Given this list of marker genes PCDHA12, CASZ1, AFF3, ELAPOR2, MSRB3, HEYL, SLC12A5, CHGA, KLK15, SH3BP5L, ALS2CL, DDN, VASH1, PRKAR2A, DSE, PCDHA13, ZNF710, CEP89, PSD3, PCDHA1, PHLPP1, PCDHA3, LMO4, POP1, FHIP2A, UNK, LPAR5, TP53INP2, PCDHA10, TRMT112, PCDHAC1, PCDHA4, BLTP2, PCDHA2, LMX1A, SH3PXD2A, TEF, ETV5 (ETS variant transcription factor 5), PRR12 (NCBI Gene Id 57479), NSMF (NMDA receptor synaptonuclear signaling and neuronal migration factor), TXNRD1 (NCBI Gene Id 7296), LIMD2, USP46, GPR132, SMNDC1, PCDHA8, CIMIP1, ZBTB39, ZNF239, IGFBPL1, PCDHA5, CASTOR2, SLC38A4, SYNJ1, KCNQ1, PAX3, FAM53C, PBX1, ARID3B, TBCEL, PIP4P1, LHFPL6, ADCY1, NUP58, MYO1B, TMEM184A, OVOL1, KCNK9, RAP1GAP, TMEM131, PCDHA11, SH3TC2, RFTN1, C2orf49, DHDDS, IST1, HSPB7, MXI1, PCDHA6, MICOS10, EDEM1, UBE2QL1, BCL2L13, COX6C, LHX1, RGP1, ZDHHC3, TRAPPC3L, PCDHA7, ADD2, SLC6A3, YEATS2, MMP28, RAB43, EPHB2, ADAMTS14, KAZN, PRDM1, ELOVL5, KIRREL3, RNF4, BSN, PTPN12, PLEKHB2, TIMM22, ATP8A2, HTR2C, EPHA10, PCDHAC2, KDM4A, GRIK3, DOCK3, PCDHA9 (NCBI Gene Id 9752), TMEM47, PTCHD4, SNX12, NUFIP2, FGF3, KATNIP, here is a description of the gene set: studied in species Homo sapiens Human Gene Set: MIR6799_3P from publication Chen Y, Wang X (PMID 31504780) Genes predicted to be targets of miRBase v22 microRNA hsa-miR-6799-3p in miRDB v6.0 with MirTarget v4 prediction scores > 80 (high confidence targets).